Given this list of marker genes Trmt10a, Rnmt, Comt, Gnmt, Prdm15, Trmt9b, Etf1, Eef2kmt, Nnmt, Mettl22, Alkbh8, Wdr6, Trmt2b, Prmt8, Wdr5, Bud23, Trmt112, Mettl23, Tmt1b, Mettl25, Fam98b, Henmt1, Ramac, Armt1, Prdm9, Setd1a, Coq5, Hemk1, Dnmt1, Ftsj3, Mettl9, Prdm5, Wdr4, Tyms, Prdm8, Setd7, Prdm12, Setd4, Mettl5, Rab3b, Inmt, Trmt6, Tyw3, Mettl24, Mecom, Tgs1, Ndufaf7, Prdm1, Mepce, Setd1b, Smyd4, Trdmt1, Mettl16, Trmt10c, Mettl18, Mrm1, Nop2, Dalrd3, Setmar, Fdxacb1, Mettl3, Ntmt1, Trmt10b, Snrpd3, Mettl2, Kmt5b, Setdb1, Eef1akmt3, Akt1, Kmt5c, Slc25a26, Trmt2a, Mettl6, Suv39h1, Thumpd3, Fbll1, Pcmt1, Prmt9, Dnmt3b, Fbl, Btg1, Dnmt3l, Tfb2m, Eef1ece2, Snrpb, Emg1, Etfbkmt, Prdm14, Pnmt, Ezh2, Coq3, Thada, Kmt2a, Icmt, Eef1akmt2 (NCBI Gene Id 72096), Bhmt (betaine-homocysteine methyltransferase), Trmt44, Mgmt, Eef1akmt1, Kmt2b, Asmt, Mettl15, Trmt5, Mtr, Tomt, Mtap, Ash1l, Mettl21e, Spout1, Larp7, Nsun4, Camkmt (NCBI Gene Id 73582), Prmt2, N6amt1, Nsun6, As3mt, Mettl8, Nsun7, Trmt11, Eef1akmt4 (NCBI Gene Id 110599566), Ndufaf5, Nsun2, Suv39h2 (NCBI Gene Id 99049), Bmt2 (NCBI Gene Id 101148), Nsd2, Bcdin3d, Ehmt2, Gm15222, Trmt13, Kmt2d, Mettl1, Prmt5, Setd6, Setdb2, Dnmt3a, Trmt12, Setd5, Trmo, Mrm3, Nsun3, Prmt6, Tpmt, Fam98a, Rab3d, Prmt1, Prmt7, Mettl21c, Ilf3, Rbm15b, Mettl21a, Dph5, Mto1, Vcpkmt, Antkmt, Kmt5a, Prdm16, Mettl14, Smyd5, Hsd17b10, Prdm4, Kmt2c, Lcmt2, Gamt, Nsun5, Pemt, Rrp8, Btg2, Dimt1, Carm1, Nsd3, Nsd1, Mettl4, Cmtr2, Comtd1, Zcchc4, Smyd3, Atpsckmt, Carnmt1, Tarbp1, Trmt1l, Prmt3, Mettl13, Trmt1, Prdm6, Gspt1, Setd2, Gtpbp3, Ntmt2, Cmtr1, Ehmt1, Larp7-ps, Pcif1, Prdm11, Prdm13, Bhmt2, Ezh1, Ftsj1, Thumpd2, Mrm2, Rbm15, Smyd2, Trmt61a, Setd3, Smyd1, Lcmt1, Rab6a, Prdm10, Hnmt, Tfb1m, here is a description of the gene set: species: Mus musculus The process in which a methyl group is covalently attached to a molecule. Mouse Gene Set: GOBP_METHYLATION